Given this list of marker genes Ddrgk1, Fbxw7, Mir744, Hcfc2, Nsd1, Dazap2, Hand1, Zbtb7c, Lif, Lamtor5, Zmpste24, here is a description of the gene set: Mouse Gene Set: GOBP_REGULATION_OF_RNA_POLYMERASE_II_REGULATORY_REGION_SEQUENCE_SPECIFIC_DNA_BINDING species: Mus musculus Any process that modulates the frequency, rate or extent of RNA polymerase II regulatory region sequence-specific DNA binding.